The following is a description of a gene set: Human Gene Set: GSE29618_MONOCYTE_VS_PDC_DN from publication Nakaya HI, Wrammert J, Lee EK, Racioppi L, Marie-Kunze S, Haining WN, Means AR, Kasturi SP, Khan N, Li GM, McCausland M, Kanchan V, Kokko KE, Li S, Elbein R, Mehta AK, Aderem A, Subbarao K, Ahmed R, Pulendran B (PMID 21743478) Systems vaccinology has emerged as an interdisciplinary field that combines systems wide measurements and network and predictive modeling applied to vaccinology. Here we used the systems vaccinology approach to study the molecular mechanisms underlying th Genes down-regulated in comparison of monocytes versus plasmacytoid dendritic cells (pDC). studied in species Homo sapiens, and this is the list of marker genes: IGKC, SPCS1, GAS6, AHI1, MCM6, TRAF4 (NCBI Gene Id 9618), LRBA, ST6GALNAC4, SNRNP25, SEL1L3, GTF2I, NREP, IRF7, IL2RG, STMN1, RGS7, FLT3, YPEL1, FEN1, ETS1, RUBCNL, VAMP1, HMHB1, FLNB, CIB2, H2BC12L, LRP8, MTMR1, CBFA2T3 (NCBI Gene Id 863), MLEC, HERPUD1, SIDT1, CCNYL7, BAHCC1, RAP1GDS1, LRRC36, LTB, DCK, LUC7L3, TSPAN13, SCT, ALOX5AP, ANKRD36, KRT5, SEPTIN6, PHEX, MAP4K1, LINC00342, CCDC186, SLC38A1, KIF5B (NCBI Gene Id 3830), VEGFB, CYFIP2, PTMS, NPC1, ANKRD36B, HSP90B1, ENPP2, EPHA2, TPM2, GOLGA8A, RPSA, SEC61B, SMC6, SERPINF1 (serpin family F member 1), HLTF, H2BC7, PHB1, AFF3, TARBP1, PHLPP2, NOP56, SCYL3, RPS6KA2, INPP4A, SLC7A11, TNFRSF21, H2BC9, ZNF22, NUCB2, PAFAH2, CLN8, IRF8, MYBL2, RIMS3, DAPK2, ADAM19, MEF2D, AUTS2, SIT1, PAIP1, MAPKAPK2, UBE2J1, SCAMP5, MREG, HYOU1, MDN1, AHNAK2, TMED10, CD2AP, ABI2, NRP1, BCL7A, ZDHHC17, TCF4, GRAMD1B, ASPH, DPP4, TMEM8B, DAB2, NDRG1, SLC7A6, GPM6B, SRP14, REPIN1, PPP1R16B, AMIGO2, OGT, AQP3, MAP2K6, ZHX2, RUNX2, DNASE1L3, SSR4, NSUN5, BLNK, PCM1, RHOH, UGCG, MYB, AEBP1 (AE binding protein 1), BCL11A, BTAF1, COBLL1, MYO1E, SLC2A1, IL18R1, IL3RA, IGHM, SINHCAF, PPIB, MZB1, SSX2IP, HMGN1, APP, ITM2C, OFD1, TNNI2 (troponin I2, fast skeletal type), LGMN, IRF4, H1-2, USP11, SETBP1, LILRA4, ST3GAL2, ATP2A3, SIGLEC6, KIF20B, CCDC88A, SEPHS1, GNG7, USP24, RBBP7, EGLN3, GPR171, HINT1, GGA2, GOLGA8B, SLC7A5, POLB, PMS2P2, PMS2P1, NGLY1, PPP1R14B, FCHSD2, FABP5, TASP1, SOX4 (SRY-box transcription factor 4), SPIB, DUSP5, PTPRS, SCN9A, EPHB1, RRBP1 (ribosome binding protein 1), TCF3, SLC9A7, ODC1, H2BC6, SFT2D2, KCNK10, HHAT, CUX2, FKBP2, LAMP5 (lysosomal associated membrane protein family member 5), MAP1A, MAGED1, ATP8A1